Given this list of marker genes HLA-G, KLRK1, LAMP1, VAV1, RASGRP4, HLA-E, IL12B, LAG3, STAT5A, KLRC4, KLRC3, CD160, KLRC4-KLRK1, KLRC2, CLNK, HLA-F, RAET1E (NCBI Gene Id 135250), PVR (PVR cell adhesion molecule), KIR2DL4, IL18RAP, IL12A, CD226, SH2D1A, KLRC1, KLRD1, NECTIN2, SH2D1B (SH2 domain containing 1B), SLAMF6, AP1G1, CRTAM, IL21, RAET1G (NCBI Gene Id 353091), NCR3, STAT5B, RASGRP1, CADM1, here is a description of the gene set: species: Homo sapiens Human Gene Set: GOBP_POSITIVE_REGULATION_OF_NATURAL_KILLER_CELL_MEDIATED_IMMUNITY Any process that activates or increases the frequency, rate, or extent of natural killer cell mediated immunity.